Given this list of marker genes Cyp2d11, Cyp2d12, Cyp2d34, Cyp2d9, Cyp19a1, Cyp2d22, Cyp2d26, Cyp2d40, Cyp2d10, here is a description of the gene set: Mouse Gene Set: GOMF_AROMATASE_ACTIVITY Catalysis of the reaction: 3 O2 + 3 reduced + testosterone = 17beta-estradiol + formate + 4 H+ + 4 H2O + 3 oxidized. Also converts androst-4-ene-3,17-dione into estrone. studied in species Mus musculus